Given this list of marker genes KCNH1, FAM171A1, NME6, TULP4, ATF2, HOXA5, NUP58, SEC22C, VLDLR, HTR4 (NCBI Gene Id 3360), SAR1A, TLCD4-RWDD3, STK40, PCYOX1, SCML4, TLR7, RHOU, TGOLN2, ZFP36L2, CA12, ELOVL7, ASH2L, USP5, PTGFR, ATP6V1H, MAN2A2, HARS2 (histidyl-tRNA synthetase 2, mitochondrial), FAM78B, ANKZF1 (NCBI Gene Id 55139), CNOT1, SLC22A23, AAK1, ALPL, USP15, NTRK3, EEPD1, HIP1, MBTD1, ZXDB, PTPRB, ZNF333, GTF2H1 (NCBI Gene Id 2965), SLC41A1, KPNA1 (karyopherin subunit alpha 1), CREBZF (NCBI Gene Id 58487), HMOX1, TSPAN2, NXPH1, CLCN5, NAB1, RAP1GAP2, FAM124A, UQCRQ, CTNNAL1, SETD5, LHX6, VPS54, ESF1, HOXD10, PAK5, SNRK, TBC1D22B, CD28, GBP6, GCC2, SESN3, PCTP, HMGCL, FBXW11, ASRGL1, KRT34, RYK, SEC22A, OLR1, TRIM33, ZFP90, SEL1L, ACE2, PHKA2, ARHGEF12, ETV5, MICOS10, SLC25A13, ISM1, SLC22A15, FUT1 (fucosyltransferase 1 (H blood group)), MXD1, GMEB1, TAF4B, SPRED3, TTPAL, SCN3B, EPHA2, LHX8, PADI1, MPP3, ABCE1, C2orf68, TNN, HEPACAM2, WDR5, GIPC3 (NCBI Gene Id 791116), RAPGEFL1, ZNF559-ZNF177, MAP3K13, CLTB, TNRC6B, TUBA4A (NCBI Gene Id 93373), SON, POFUT2, DIRAS2, SPOCK1, KIAA0930, HEYL, PLXND1, NFASC, RPGRIP1L, CERS6, SKP2, ILDR2, ZNF182, SNX27 (sorting nexin 27), STX3, SNX6, RPRD2, PAFAH1B1, CELF1, ABHD2, PPARA, PATE4, RB1, MYOZ3, ANKS4B, PHF13, EXOC6, TMEM87B, INPP5K, PRDM1, DRP2, PLSCR4, SH3GL3, OTX2, RPUSD3, BACE2, ACSBG1, PPP2R5E, PPP1CC, MEIOB, CEP19, SMC1A, CDK13, WIPF2, SEPTIN11, SPATA6, DCUN1D5, CYB5D1 (NCBI Gene Id 124637), RASGRP1 (RAS guanyl releasing protein 1), MLLT1, ZNF177, here is a description of the gene set: Genes predicted to be targets of miRBase v22 microRNA hsa-miR-520a-5p in miRDB v6.0 with MirTarget v4 prediction scores > 80 (high confidence targets). species: Homo sapiens Human Gene Set: MIR520A_5P from publication Chen Y, Wang X (PMID 31504780)